The following is a description of a gene set: studied in species Homo sapiens Follicular hyperkeratosis A skin condition characterized by excessive development of keratin in hair follicles, resulting in rough, cone-shaped, elevated papules resulting from closure of hair follicles with a white plug of sebum. Human Gene Set: HP_FOLLICULAR_HYPERKERATOSIS, and this is the list of marker genes: GJB6, FKBP14, KRT17, MBTPS2, CDH3, PSENEN, SREBF1, GJB2, TRIP4, DDR2, KRT81, PKP1, KRT83, NLRP1, KRT16, KRT86, WNT10A, LRP1, DSC3, RHBDF2, CAST, KRT6B, COL6A1, PLOD1, KRT6A, DSG4, RBP4 (retinol binding protein 4), POFUT1, TARS1, SLC27A4